Given this list of marker genes FGF18, FGF17, FGFR3, FGF8, FGF1, FGF20, FGF9, here is a description of the gene set: Human Gene Set: REACTOME_FGFR3B_LIGAND_BINDING_AND_ACTIVATION species: Homo sapiens FGFR3b ligand binding and activation